The following is a description of a gene set: Fetal onset species: Homo sapiens Onset prior to birth but after 8 weeks of embryonic development (corresponding to a gestational age of 10 weeks). Human Gene Set: HP_FETAL_ONSET, and this is the list of marker genes: RNU4-2, TRPV6, SYNE1, CREB3L1, EZH2, GINS1, B4GAT1, TBX5, ERF, MAP3K7, KDM6A, GBE1, TBXT (NCBI Gene Id 6862), B9D1, SCN4A, ACTA1, POMK, NUP155, PIGA, KDELR2, TAF2, NDUFB11, RAB34, CDC42BPB, ZIC3 (Zic family member 3), WDR4, RECQL4, PLG, CNTNAP1, PI4KA, RMRP, CALM2, BMPER, DYNC2LI1, CHD7, WNT3, TWIST2, PIGG, PWAR1, ESAM, CCDC134, MYH11, CHD8, KIF20A, KIDINS220, STRA6, FKBP14, PRKAG2, TNFRSF11A, NSD2, RAD21, FZR1, ACTG2, RIPK4, BICD2, FH, FTO, WT1, DVL1 (dishevelled segment polarity protein 1), CC2D2A, STT3B, TCTN3, PPP1CB, ZNF526, CLPB, NUP88, CENPE (centromere protein E), MDFIC, ADGRG6, L1CAM, RYR1, NEK8, OBSL1, VRK1, NSD1, FANCB, PLXND1, DEF6, PRIM1 (NCBI Gene Id 5557), PLCH1, MKS1, SOS1, CRB2, GLDN, FARSB (phenylalanyl-tRNA synthetase subunit beta), LBR (NCBI Gene Id 653311), KMT2D, ZSWIM6 (zinc finger SWIM-type containing 6), IFNG, MRPS22, RRAGC, PRRX1, MEGF10, IL6ST, ZMPSTE24, KIF7 (NCBI Gene Id 46), COG8, ASPM (assembly factor for spindle microtubules), LGI4, MPDZ, P3H1 (NCBI Gene Id 64175), NRAS, TBX18, PWRN1, TOGARAM1 (TOG array regulator of axonemal microtubules 1), NADK2, SIN3A, RAC1, KLF1, KIF14, XYLT1, CRLS1, SERPINH1, RPL26, NDUFB7, TRAIP, PDX1, USP18, EXOC7, DCC, COX16, RNF2, TRIP11, SNORD115-1, ERCC8, RPL10, COL2A1, SC5D, LMOD1, IFIH1, THSD1, BRD4, ROBO1 (roundabout guidance receptor 1, NCBI Gene Id 6091), SNAP25, EXOSC9, LZTR1 (leucine zipper like post translational regulator 1), ATP1A2, KIAA0753 (NCBI Gene Id 9851), SRPK3, TPM1, ALG8, MESP2, MKRN3, ERCC5, SOX18, GUSB, SLC25A19, ALPK3, TSC2, PLEC, COASY, TXNDC15, ASNS, GFRA1, IARS1, KMT2B, SHQ1, SLC35D1, DLL3, LMNA, PYCR1, MYRF, TMEM216, TNNT2, GBA1, SKIC2, CPSF3, GRIP1, SMAD2, SOX10, SYT2, DEPDC5, FGFR3, CPT2, PPP3CA, WDR19, ADCY6, SLC35A3, B9D2, SNORD116-1, CCDC88C, SLC12A1, ZIC2, UBR1, MCM10, SDHD, SCN5A, CHUK, MAGEL2, SLC30A9, ALG1, PLOD3, PPIB, FARSA, HERC2, COQ4, CHRNG, SDHA, ALX4 (ALX homeobox 4), GNPTAB, NPAP1, PAICS, KIF5C